The following is a description of a gene set: A proton-transporting two-sector ATPase complex that catalyzes the phosphorylation of ADP to ATP during oxidative phosphorylation. The complex comprises a membrane sector (F0) that carries out proton transport and a cytoplasmic compartment sector (F1) that catalyzes ATP synthesis by a rotational mechanism; the extramembrane sector (containing 3 a and 3 b subunits) is connected via the d-subunit to the membrane sector by several smaller subunits. Within this complex, the g and e subunits and the 9-12 c subunits rotate by consecutive 120 degree angles and perform parts of ATP synthesis. This movement is driven by the hydrogen ion electrochemical potential gradient. species: Homo sapiens Human Gene Set: GOCC_PROTON_TRANSPORTING_ATP_SYNTHASE_COMPLEX, and this is the list of marker genes: MT-ATP8 (NCBI Gene Id 4509), ATP5MJ, ATP5ME, DMAC2L, ATP5F1B, ATP5MC1, ATP5MK, ATP5F1A, ATP5MGL, ATP5MF, ATP5F1C, ATP5PB, ATP5MC3, ATP5PO, ATP5MG, MT-ATP6, ATP5MC2, ATP5F1E, ATP5F1EP2, ATP5PD, ATP5PF, ATP5F1D